The following is a description of a gene set: species: Homo sapiens Enlargement of the cardiac ventricular muscle tissue with increase in the width of the wall of the ventricle and loss of elasticity. Ventricular hypertrophy is clinically differentiated into left and right ventricular hypertrophy. Human Gene Set: HP_VENTRICULAR_HYPERTROPHY Ventricular hypertrophy, and this is the list of marker genes: TTN, ABCA3, KDM6A, RAP1B, SLC25A24, MYL2, WDR35, RPL5, TRMT10C, HADHB, NPHP3, COL1A2, ESPN, SFTPB, INSR, MYH7, ABCA1, RRM2B, HCN4, FBXL4, CPT2, ATP13A3, TBX1, MT-TV, DTNA, IPO8, BBS1, MTX2, RNU7-1, SLC2A10, SDHB, KCNJ5, LMNA, GLA, MT-TC, MYOZ2, POLG, MT-TS2, PIGN, VIPAS39, TTR, NSMCE2, MEN1, ATP6V1E1 (NCBI Gene Id 529), EGFR, B3GAT3, HSD11B2, ZMPSTE24, JPH2, NKX2-6, LOX, POMT2, SGCG (NCBI Gene Id 6445), AGL, MT-CYB, SCO1, GAA, NDUFA11, LRPPRC, KMT2D, FZR1, AIP, GYG1, TNNT2, SMAD3, MT-ND6, DEPDC5, SCN5A, CCDC28B (coiled-coil domain containing 28B), MT-ND5, RYR1, GLRX5, STAMBP, ARL6, NEK8 (NIMA related kinase 8), TLL1, GYS1, FOXF1, FHL1, PRKAG2, POLR1A, ALPK3, BMPR2, MT-TQ, NKX2-5, GTPBP3 (NCBI Gene Id 84705), ADAM17, SDHAF1, SGCD, SLC25A12, ENPP1, LDB3, ACTC1, MT-ND1, DMD, FLNC, BIN1, GPC3, TCAP, SELENON, MT-TK, DEF6, COX6B1, CHST3, SMAD2, HADHA, GPR101, PLN, LZTR1, ZNF462, FKRP, TPK1, C1QBP, TNNC1, TWNK, MT-TL1, POLG2, SLC25A20, SDHD, MYRF, PSEN1, GNPTAB, COG1, PLXND1, SVIL, ACTN2, SPEG, MYBPC3, ARSK, NHLRC2, NPPA, COLQ (collagen like tail subunit of asymmetric acetylcholinesterase), PIGA, TNNI3 (NCBI Gene Id 7137), DBR1, CAPNS1, ABCC9, MYL3, RIT1, ZNF687, MT-TW, MT-TF, MT-CO2, NONO, CACNA1D, NEXN, COX7B, MYPN, MYH6, SLC25A4, PSEN2, WAC, GPC4, VPS33B, MT-CO1, SCO2, COX16, NOTCH1, COQ9, LAMB2, NDUFS2, MT-CO3, LTBP4, POMT1, MOGS, SDHA, EPG5, TALDO1, NAXD, NOD2, DYSF (NCBI Gene Id 8291), COQ7, ALG12, ATP6AP2, ABCC6